The following is a description of a gene set: species: Mus musculus from publication Chen Y, Wang X (PMID 31504780) Genes predicted to be targets of miRBase v22 microRNA mmu_miR_32_3p in miRDB v6.0 with MirTarget v4 prediction scores > 80 (high confidence targets). Mouse Gene Set: MIR_32_3P, and this is the list of marker genes: Ndnf, Fgl2, Mbnl2 (muscleblind like splicing factor 2), Jade3, Dcbld2, Tmtc3, Ngf, Zbtb10, Gdf10, Srsf6, Mbnl3, Sema3a, Rab7, Mycbp2 (NCBI Gene Id 97940), Tshr, Sgms1, Yaf2, Zbtb11, Pdzrn3, Hecw2, Gabarapl2, Pla2g3, Stradb, Cenpu, Ficd, Trp53i13, Nhlrc2, Mtm1, Srsf1, Pibf1, Pip4k2c, Acvr2a, Gabrb2, Relch, Apc, Nat2, Ro60, Klhl31, Stox2, Sh3bp1, Ranbp3l, Ddx60, Tpbg, Bcl11b, Cnep1r1 (NCBI Gene Id 74731), Lrrc72, Inpp4b, Atrx, Epc1, Tmtc2, Dmrta1, Prkaa2, Smndc1, Tacc3, Pcdh11x, Foxg1, Artn, Fkrp, Rrm2b, Hopx, Ankrd28, Atp5f1c, Usp37, Ppp1r8, Lats2, Simc1, Chd1, Rfpl4, Tead1, Tanc2, Sec24d (NCBI Gene Id 69608), Ppargc1a, Igf2bp3, Acbd5, Hyal2, Nin, Kif5b, Osbp, Ralgapa1, St6gal1, Zc3h6, Pcdh19, Fgfr4, Kazn, Zbtb33, Srgap1, Slk, Mmd, Lrig3, Inppl1, Col1a2, Celsr1, Ltn1, Gopc, Agtpbp1, Cep97, Snx18, Lgr4 (leucine-rich repeat-containing G protein-coupled receptor 4), Morf4l2, Dynlt1b, Lrrc28, Usp42, Pacc1, Naa30, Mtdh, Pxmp4, Togaram1, Cnot7 (NCBI Gene Id 18983), Mybl1, Actr2, Rnf103, Kras, Ube2c, Pom121, Arih1, Tmem45a, Ifih1, Dnajc21 (DnaJ heat shock protein family (Hsp40) member C21), Csn1s1, Fgf4, Dr1, App, Nr4a3, Six1, Ntf3, Ppp2r2a (protein phosphatase 2, regulatory subunit B, alpha), Nup205, Sbno2, Lin54, Fgg, Fut9, Cd84, Arhgef28, Kcnj16, Smcr8, Pafah1b1, Nudt4, Actb, Ndufs2, Jakmip3, Vapb, Mmrn1 (NCBI Gene Id 70945), Ociad1, Ppp2cb, Lyn, Csgalnact2, Meioc (meiosis specific with coiled-coil domain), Ndfip2, Srrm1, Tnfaip3, Bmt2, Tshz3, Plppr5, Socs6, Emc7, Camk2d, Pank3, Ctdspl2, Tmem108, Larp4b, Epb42, Ccdc88a, Srsf11, Tuft1, Sgpp1, Adamts6, Thbs2, Tex12, Elovl7, Med13, Ppm1d, Kpna4, Jam3, Gnptab, Chrdl1, Dock5, Crebzf, Ccr1, Vta1, Rflnb, Scrn1, Trappc6b, Ppp6c